The following is a description of a gene set: Abnormal internal carotid artery morphology species: Homo sapiens Human Gene Set: HP_ABNORMAL_INTERNAL_CAROTID_ARTERY_MORPHOLOGY An abnormality of an internal carotid artery., and this is the list of marker genes: NF1, LDLR, LDLRAP1, ABCG8, PCSK9, ABCG5, NDE1, APOB, LMX1B, HOXA1, ADA2